Given this list of marker genes TMEM132A, VPS35, WLS, OPRM1, PTPN23, here is a description of the gene set: Human Gene Set: GOBP_REGULATION_OF_WNT_PROTEIN_SECRETION species: Homo sapiens Any process that modulates the frequency, rate or extent of the controlled release of a Wnt protein from a cell.